Given this list of marker genes Id1, Mapk1, Tasp1, Lhx5, Mon2, Tmem68, Creld2, C1qbp, Tmem39a, Rasef, Scx, Ncoa2, G2e3, Eif4g3, Fam76b, Rab14, Cldn12, Laptm4a, Utrn, Bdnf, Aak1, Hnrnpd, Tle4, Abcb1a, Ube2h, Lats1, Rfx7, Rtn1, Nxt2, Vkorc1l1, Olfm3, Bmpr1a, Txlng, Ubl3, Spen, Naaladl2, Mycbp2, Tra2a, Cnbp, Pdzrn3 (PDZ domain containing RING finger 3), Sgtb, Zfp704, Sp9, Erf, Plppr5, Gramd4, Slc10a4, Psd2, Mcu, Ercc5, Zfp518a, Ube2b, Cilk1, Grk5, Zbtb14, Emp2, Clca3a2, Nlgn1, Lysmd3, Ik, Usp12, Carmil1, Pnisr, Efcab2, Ppp1r21, Prdm16 (PR domain containing 16), Yy1, Zmiz1, Arhgap20, Thbs2, Ncapg2, Gng2, Zfp219, Olfml2b, Ralgds, Syvn1, Nkiras1, Mecom, AI597479, Gdap2, Crebzf, Dnali1, Sspn, Septin9, Fbxo38, Akap6, Nr5a2, Dll1, Cdk2ap2, Dlx2, Cacna1b, Tm4sf4, Fbxo8, Cnot6 (CCR4-NOT transcription complex, subunit 6), Wdr26, Vezf1, Fa2h, Hikeshi, Ctla4, Mpv17l, S100pbp, Aktip, Col11a1, Rcan2, Trpm7, Ccdc126, Atp6v1h, Ccny, Cnksr3, F3, Mdm1, Grm5, Cfl2, Unkl, Tcf20, Ormdl1, Myt1l (NCBI Gene Id 73066), Cdc42ep3, Nrp2, Ino80d, Rictor, Ubxn7, Cbx5 (NCBI Gene Id 97945), Nfat5, Phyhipl, Pyroxd1, Igf1r, Tbc1d15, Srsf11, Eea1, Mid2, Kdm6a, Pum2, Neurog2, Adcyap1, Hbp1, Pik3c2a, Tle1, Zfp248, Cep72, Rif1, Plpp3, Bnc1, Edil3, Kpna3, Rev3l, Zfpm2, Tusc3, Tnfrsf11b, Slc20a2, Btbd1, Spry2, Cecr2, Gria3, Sfrp2, Skint10, Tab3, Gpr37, Acr, Tm7sf3, D630023F18Rik, Ice1, Dcun1d4, Nckap5, Selenok, Lrrc1, Paxbp1, Rnf24 (ring finger protein 24), Syngr3, Spata13, Cpeb3, Bfar, Efna5, Adss2, Mfsd1, Plekhm3, Srsf1, Ccrl2 (NCBI Gene Id 73654), Tgfb3, Ptpra, Taok1, Rhoa, Ebf3, Dennd4a, Arhgef33, Tet3, Dcbld2, Psip1, Spred1, Hectd2, Sephs1, Btg2, Psmd5, Zbtb49, Akap1, Adamts5, Foxd3, Opa1, Zcchc24, Klhl2, Cpne2, Mageb16, Dmtf1, Btaf1, Klf4, Tead1, Smo, Nr2f2, Syt14, Efs, Dmxl2, Sbno1, Kif11, Hook3, Zbtb41, Aqr, Wdr35, Ubn1, Syf2, Apaf1, Pabpc4l, Irx3, Sox9, Asic4, Gnpat, Zic1, Cpsf6, Pias1, Gata3, Spry1, Spock3, Hip1, Cpeb2, Dcc, Sfpq, Ppp1r2, Kdm2b, Cert1, Tjp1, Myct1, Car10, Ssb, Ciart, Casp8ap2, Tns3, Inpp4a, Zfyve16, Slc18a2, Dock11, 9330159F19Rik, Trpc5, Wac, Il10rb, Pde10a, Magi1 (membrane associated guanylate kinase, WW and PDZ domain containing 1), Larp4b, Hacd2, Ripply2, Rad21, Bnip2, Uox, Scn2a, Pfkfb3, Eps15l1, Gpalpp1, Golim4, Ankrd44 (ankyrin repeat domain 44), Acvr1, Lemd3, Bmal1, Sp4, Arih1, Rsf1, Cadm1, Usp42, Tec, Atad5, Oxr1, Arfip2, Klhl7, Cntrob, Spin1, Zfp280d, Brd1, Rsrp1, Snx14, Akap12, Unc79 (NCBI Gene Id 217843), Kmt2c, Adcy6, Cnot6l, Kdm7a, Bach2, Zfp318, Gp1ba (NCBI Gene Id 14723), Wdhd1, Usp32, Arhgef3, Rbbp6, Mark1, Atf2, Sanbr, Zfp800, Basp1, Ppp4r3b, Rprd1b, Golga7, Sh3gl3, Nudt4, Npbwr1, Rhot1, Nasp, Dennd2b, Chd1, Rabggtb (Rab geranylgeranyl transferase, b subunit), Ubn2, Actr3 (NCBI Gene Id 74117), Myf5, Mycl, Dek, Prr12, Thoc1, Hectd1, Uty, Ifit1bl1, Rrm2b, Tubgcp5, Col13a1, Rb1cc1, Ubtf, Fnip1, Bmpr2, Npy1r, Camta1, Scai, Hycc2, Mast4 (microtubule associated serine/threonine kinase family member 4), Ptms, Pcdh8, Xpo7, Plcl2, Fzd6, Itga6, Bltp1, Mllt6, Usp25, Snrpb2, Nphp3, Nfkbia, Nr3c1, Cftr, Csnk1g3, Nktr, Cnr1, Ppp1r15b, Sall3, Nexmif, Rab6b, Clspn, Ppp3ca, Rnf144a, Jph1, Rab10, Pcgf5, Slc25a40, Cnnm4 (cyclin M4), U2surp, Smyd3, Smarca5, Oosp1, Tecrl, Frs2, Atad2, Armc10, Frem2 (Fras1 related extracellular matrix protein 2), Plag1, Rab3gap2, Ier5, Lrp1b, Map2, Kctd12, Lgr4, Pcdh11x, Traf3ip1, Ap1s3, Fbxo43, Rcc1, Fgfr2, Rnf170, Appl1, Mospd2, Plekha6, Hhip, Foxn2, Tcf3 (NCBI Gene Id 21423), Grhl3, Gls, Gtf2i, Mex3b, Psd3, Dgkd, Hnrnpa1, Gulp1, Etl4, Myo5a, Crk, Slc39a10, Dach1, Tut4, Ppp1r3b, Hivep2, Dock1, Klhl24, Il4, Nkx2-9, Mitf, Tbc1d4, Slc8a1, Rbm46, Nfatc3, Fbxo34, Bdp1 (NCBI Gene Id 544971), Mdm4, Srsf2 (NCBI Gene Id 28128), Cand1, Capza2, Zmynd8, Zfyve21, Polr2k, Golga2, Lrp6, Plk1, Camk2d, Btf3l4, Jag2, Med14, Mllt10 (NCBI Gene Id 338532), Tasor, Pafah1b1, Ppp1r3f, Ptpre, Rnf38, Fndc3a, Akap9, Abcd3, Cul1, Tmem26, Rerg, Foxp1, AI182371, Cdc14b, Ptbp3, Prpf38b, Il5ra, Ikzf2, Mtf1, Foxo1, Dcaf7, Nptn, Gabrg1, Tpm1 (NCBI Gene Id 97508), Hmgxb4, Herc1, Hcrtr2, Arhgap44 (Rho GTPase activating protein 44), Dcaf6, Hdac9, Cwc22, Vcf2, Rab11fip3, Add3, Hes1, Wnt5a (NCBI Gene Id 77565), Cabp4, Ano4, Thrb, Ppfia2, Hmgcr, Slc25a16, Slc6a17, Qki, Ppp4r2, Erbin, Mt4, Btbd3, Pum1, Unc119b, Tmtc2 (transmembrane and tetratricopeptide repeat containing 2), Tcerg1l, Ythdf3, Rab11fip2, Mycn, Col4a1, Isoc1, Ccnq, Ddx21, Hivep1, Dcaf1, Pou2af3 (POU class 2 homeobox associating factor 3), Kbtbd2, Cdh20, Fmnl3, Acvr2b, Ubr1, Kmt2e, Mageb3, Man1a2, Mef2d, Nbea, Herc2, Arid4b, Mblac2, Zmat1, Slain2, Rnf115, Sde2, Jag1, Calu, Stk40, Zfp850, Usp31, Mmab, Cab39, Prkacb, Slc38a9, Rnf223, Tob1, Pdia3, Mbnl2, Ube3c, Itm2c, Fabp3, Fosl2, Map4, Bhlhe40, Cacna2d1, Col1a2, Pm20d2, Lin9, Cntn1, Dll4, Glcci1, Fbxo45 (NCBI Gene Id 75407), Setdb2, Cry1, Nup35, Nudt11, Kcnip2, Zmym6, Myo9a, Npr3, Fli1, Arap2 (ArfGAP with RhoGAP domain, ankyrin repeat and PH domain 2), here is a description of the gene set: studied in species Mus musculus Mouse Gene Set: LET_7F_1_3P Genes predicted to be targets of miRBase v22 microRNA mmu_let_7f_1_3p in miRDB v6.0 with MirTarget v4 prediction scores > 80 (high confidence targets). from publication Chen Y, Wang X (PMID 31504780)